Given this list of marker genes RGS9, CNGA3, GRK1 (NCBI Gene Id 6011), GNB3, GUCA1C, GUCA1B (guanylate cyclase activator 1B), CNGB3, PDE6C, GUCA1A, LRAT, RPE65, ARR3, SLC24A2, GNB5, GNGT2, GNAT2, RDH5, GUCY2F, GRK7, RGS9BP (regulator of G protein signaling 9 binding protein), PDE6H, RDH12, GUCY2D, here is a description of the gene set: Human Gene Set: PID_CONE_PATHWAY from publication Schaefer CF, Anthony K, Krupa S, Buchoff J, Day M, Hannay T, Buetow KH (PMID 18832364) studied in species Homo sapiens Visual signal transduction: Cones